The following is a description of a gene set: A protein complex whose core components are the receptor-interacting serine/threonine-protein kinases RIPK1 and RIPK3 (also called RIP1 and RIP3). Formation of the ripoptosome can induce an extrinsic apoptotic signaling pathway or a necroptotic signaling pathway. The composition of this protein complex may depend on several factors including nature of the signal, cell type and more. studied in species Homo sapiens Human Gene Set: GOCC_RIPOPTOSOME, and this is the list of marker genes: CASP8, CFLAR, FADD, TICAM1, CASP10, RIPK1